Given this list of marker genes Pparg, H4c9, H2bc13, H4c4, H2ac19, H4c17, H2bc12, H4c1, H3f3a, H3c7, H2ac4, H3c11, H2ac23, H4c3, H2ac22, H3c2, H2ac24, H2ac12, H2bc27, H4c18, H2bc1, H2bc22, Ncor2, H2ac10, H3c4, H3c6, Gps2, H3c13, H3c10, H4c8, H2bc3 (H2B clustered histone 3), H2ac13, Hdac3, H2bc15, H2bc9, H2ac11, H2az2 (H2A.Z histone variant 2), H3c1, H4c12, H2ac15, H4c2, H2ac20, H2bc7, H2ac7, Tbl1x, H2ac6, H2ac8, H4c6, H3c8, H2ax, H4c14, H3c3, H4c11, H2ac1, H2bc8, H3c15, H2bc11, here is a description of the gene set: part of: Epigenetic regulation of adipogenesis genes by MLL3 and MLL4 complexes This event has been computationally inferred from an event that has been demonstrated in another species.<p>The inference is based on the homology mapping from PANTHER. Briefly, reactions for which all involved PhysicalEntities (in input, output and catalyst) have a mapped orthologue/paralogue (for complexes at least 75% of components must have a mapping) are inferred to the other species. species: Mus musculus electronically inferred by orthology from the curated human pathway Reactome Pathway: MLL4 and MLL3 complexes regulate expression of PPARG target genes in adipogenesis and hepatic steatosis